Given this list of marker genes RUNDC3A, CA7, TMEM54, TRIM8, FAP, PLEC, HDAC3, ROM1, BTK, STAT5B, GJB3, KCNH6, PKP3, PHLDA2, ABCD1, HSPB8, ELK3, LAMC1, DHRS3, RIT1, CIMAP2, ABHD4, ITPKC, TENT5B, CILK1, LTBP3, COBL, WNT6, ORAI1, XPOT, ATP1B1, ETV5, KLHL40, KLHL41, SFN, PVALB, EIF3J, PEA15, TAGLN2, TGFBR2, NR0B2, NDRG2, NFRKB, VGF, SCOC, SLC35E4, LRRFIP2, ATXN7L2, ZNF516-DT, CAMKK1, P2RX6, SLC16A6, PSME4, SPARC, CMAS, VIM, DMPK, ADORA2A (adenosine A2a receptor), TPP1, PKN3, CYTOR, OLR1, PLCD1, SLC4A11, USP13, BUD31 (NCBI Gene Id 8896), SCEL, NDP, COA3, NR1D1, APOBEC1, TMEM151A, CPA6, LINC02694, ABHD2, GAB2, RIPK4, LAPTM5, GADD45A, SMARCA2, SLC26A1, DCTN2, ALDOA, BMP2, C2CD2L, TMCC1, RBPJ, TFE3, IL1RN, ECM1, SCRN1, DCN, YIF1A, VASP, TINAGL1 (NCBI Gene Id 64129), TIAL1, BAZ2A (NCBI Gene Id 23525), RTN4, CRACDL, ANXA7, CAPNS1, FERMT3, PSMD11, SFTPC, LAMA3, DSTN, LYVE1, RNF182, CDKN1A, PPP2CA, AP2B1 (adaptor related protein complex 2 subunit beta 1), PSMD7, GFAP, GNAI1, SPATS2, GTF2B, GGN, CA9, S100A5, GPAT3, OMG, DIAPH1, SLC9A5, VAMP5, RB1CC1, ZNFX1, SNCB, NRIP3, UCN2, EFNA1, SBSN, SHC3 (NCBI Gene Id 53358), IL9, CLSTN3, TSKU, YWHAZ, MMP7, PDGFRB, ST18, PTPRH, PIANP, C1QTNF8, C3AR1, KDM3A, NCDN, REXO2, KBTBD8, CYFIP1, ABCA2 (ATP binding cassette subfamily A member 2), TBC1D17, COL27A1, AP2A2, TCF12, MAP1A, IDS, PTPRN, MAP4, ENO1, MAP2, RCAN2, MARK1, FGF12, NEFH, ZFAND5, AK5, WDFY3, LPP, TRAF3, RAB3D (NCBI Gene Id 9545), MYBPH, CDK14, FBXW11, KCNA2, RELL2, CASK, ZNF385B, HOXD3, GPX1, SLC25A51, EEF1A2, EIF4E, PSMD4, UCHL3, SYT2 (NCBI Gene Id 6858), CCDC50, PLBD2, MAPK3, TUBA4A, RGS8, TUBA4B, NECAB3, GAPDH, RAB30, NEK6, DIRAS1 (DIRAS family GTPase 1), BLMH, KRT86, STK40, RBBP7 (NCBI Gene Id 5931), COQ8B, HOXA11, IL23A, PSMD12, CRYBA2 (NCBI Gene Id 1412), PAPPA, CNTD1, PDAP1, ZBTB2, MPRIP, AKT1S1, PTP4A1, ROCK2, ABI3, PDZD9, VDR, RIN1, TEX19, LMNA, TRIB1, LINC02908, KCNK10, ZNF436, DCHS1, PITPNC1, NFATC4, GPR3, TOR4A, SPATA16, PCDH9, TOR1AIP2, STX17, PRDM1, PADI4, ZNF771, POLR3E, DTNA, TLL1, LAMC2, HSPB7, FLNC, SYTL1, PRR7, FHL3, PSMD2, BICDL1, WDFY3-AS2, HS3ST2, AXIN2, UBE2C, MMP9, RIMS1, EPHA2, CELA1, TRPV3, RNF144B, IGSF9, PAK6, MDFI, UBQLN1, DYNC1H1, here is a description of the gene set: Genes having at least one occurrence of the motif NNTGACTCANN in the regions spanning 4 kb centered on their transcription starting sites. This matches the JUN transcription factor binding site V$AP1_Q6 (v7.4 TRANSFAC). studied in species Homo sapiens Human Gene Set: AP1_Q6